Given this list of marker genes WARS2, DARS2, YARS2, TARS2, GARS1, SARS2, EARS2, AARS2, here is a description of the gene set: The synthesis of aminoacyl tRNA by the formation of an ester bond between the 3'-hydroxyl group of the most 3' adenosine of the tRNA, to be used in ribosome-mediated polypeptide synthesis in a mitochondrion. species: Homo sapiens Human Gene Set: GOBP_TRNA_AMINOACYLATION_FOR_MITOCHONDRIAL_PROTEIN_TRANSLATION